The following is a description of a gene set: species: Mus musculus The biological process whose specific outcome is the progression of a bronchiole from an initial condition to its mature state. This process begins with the formation of the bronchiole and ends with the mature structure. A bronchiole is the first airway branch that no longer contains cartilage; it is a branch of the bronchi. Mouse Gene Set: GOBP_BRONCHIOLE_DEVELOPMENT, and this is the list of marker genes: Fgf10 (NCBI Gene Id 14165), Tgfb1, Hoxa5, Itgb6, Tcf21, Mmp12 (matrix metallopeptidase 12)